The following is a description of a gene set: Mouse Gene Set: chr7B1 studied in species Mus musculus, and this is the list of marker genes: Scgb2b28-ps, Pmis2, Scgb2b20, 1110035H17Rik, Scgb2b4-ps, Wdr87-ps, Zfp260, Scgb2b30, Mif-ps4, Gm5116, Scgb1b22-ps, Gm9162, 1700020L13Rik, Sars2, Scgb2b1 (NCBI Gene Id 100043827), Scgb2b13-ps, Hspb6, Gm4883, Scgb2b27, Scgb1b3, Nfkbid, Zfp382, D7Ertd128e, Kcnk6, Scgb2b11, Gm12774, Eif3k, Rpl23a-ps11, Igflr1, Gm5732 (predicted gene 5732), Gm44700, Nphs1os, Gm4373, Mir7049, Gm57504, Rbm42, Gm9146, Lsr (lipolysis stimulated lipoprotein receptor), Mir1963, Mrps12, Ech1, Gm5113, Scgb2b32-ps, Scgb2b7 (NCBI Gene Id 100044348), Zfp36, Catsperg1, Yif1b, Scgb2b31-ps, Polr2i (NCBI Gene Id 69920), Gm12757, 4930432E11Rik, Scgb1b20, Ffar2, Scgb1b30, Scgb2b16-ps (secretoglobin, family 2B, member 16, pseudogene), Gmfg (glia maturation factor, gamma), Gm28384, Pdcd2l, Gm12763, Gm12778, Zfp420, Spint2, Pak4, Rpl23a-ps12, Cd22, Usf2-ps1, Upk1a, Gm9142, Mag, Zfp27, Zfp566, Scgb1b29, Mir3569 (NCBI Gene Id 102465774), Gm6669, U2af1l4, Gramd1a, Garre1, Rasgrp4, Kmt2b, Fam98c, Samd4b, Gm5731 (predicted gene 5731), Wdr62, Scgb1b26-ps, Ggn, Gm29263, Gm12768, Scgb1b27, Psmd8, Tyrobp, Rps12-ps4, Zfp940, Gm21135, Scgb2b12, Cox6b1, BC060293, Gm19880, Scgb2b21, Scgb2b2, Lgals4, Scgb2b17, Gm29627, Scgb2b6, Spred3, Ifnl2, Ccer2, Gm9569, Sbsn, Gm12755, Scgb1b10, Scgb1b34-ps, Gm21673, Zfp383, Hamp, Ryr1, Usf2, Fxyd7, Zbtb32, Atp4a, Scgb2b33, Zfp568, Krtdap, Med29, Scgb1b7, Dmkn, Scgb1b15, Gm38979, Lrfn3 (NCBI Gene Id 233067), Mir7668, Gm5058, Fam187b, Gm12782, Scgb2b22-ps, Rpl23a-ps8, Arhgap33os, Map4k1, Kirrel2, Scgb1b13-ps, Mir7050, Sipa1l3, Actn4, Rps12-ps5, Lgals7, Gpi1 (glucose-6-phosphate isomerase 1), Gm9127, Gm9114, Gm10988, G630030J09Rik, Zfp146, Scgb2b10, Gm30646, Sycn, Hpn, Gapdhs, Scgb1b24, Zfp84, Gm9156, Gm5327 (NCBI Gene Id 635421), Nfkbib, Scgb1b6-ps, Ifnl3, A330087D11Rik, Gm26604, Scgb2b25-ps, Zfp790, Psenen, Etv2, Ffar3, Scgb2b15, Nccrp1, Nphs1, 1700019A23Rik, Sirt2, Gm12770, Gm28257, Syne4, Gm6518, Rinl, Lrfn1, Scgb1b17, Gm37292 (predicted gene, 37292), Arhgap33, Proser3, 2310043P16Rik, Uba2, Capns1, Scgb1b21, Scgb1b2, Ppp1r14a, Gm6096, Ovol3, Gm10648, Zfp82, Rpl23a-ps7, Acp7, Gm6579, Scgb2b24, Clip3, Fxyd1, Lgi4, Mir1964, Hamp2, Wtip, Gm12764, 4930479H17Rik, Cox7a1, Lin37, Scgb2b26, Gm28408, Scgb1b8-ps, Zfp30, Gm5329, Gm9149, Gm25259 (NCBI Gene Id 115486693), Scgb2b23-ps, Gm4398, Gm29492, 1700028B04Rik, Aplp1, Dpf1, Rpl23a-ps9, Zfp74, Gm12760, Gm9120, Haus5, Ffar1, Fxyd3, Gm12762, Rpl23a-ps10, Gm9135, Tbcb, Prodh2, Sdhaf1, Fbxo27, Tmem147os, Alkbh6, Scn1b, Scgb1b19, Scgb1b12, Scgb2b8-ps, Hnrnpl, Gm9167, Catsperg2, Hcst, Lsm14a, Scgb2b29-ps, Mir9769, 2200002D01Rik, Fbxo17, Scgb2b19, Capn12, Scgb2b9-ps, Gm12773, Tmem147, Zfp14, Fxyd5, Scgb2b3, Gm12758, 2200002J24Rik, Gm6003, Gm4405, Paf1 (Paf1, RNA polymerase II complex component), Scgb2b18, Scgb2b14-ps